Given this list of marker genes Mad2l2, Ovol2, Bhlhe41, Creb1, Dach1, Hdac2, Phb1, Tfap2a (NCBI Gene Id 21418), Hdac4, Muc1, Smad7, Kdm2a, here is a description of the gene set: species: Mus musculus Mouse Gene Set: GOBP_NEGATIVE_REGULATION_OF_TRANSCRIPTION_BY_COMPETITIVE_PROMOTER_BINDING Any process that stops, prevents, or reduces the frequency, rate or extent of DNA-dependent transcription using a mechanism that involves direct competition for interaction with a promoter binding site.